The following is a description of a gene set: Human Gene Set: GOBP_SOFT_PALATE_DEVELOPMENT The biological process whose specific outcome is the progression of the soft palate from an initial condition to its mature state. This process begins with the formation of the structure and ends with the mature structure, whatever form that may be including its natural destruction. The soft palate is the posterior portion of the palate extending from the posterior edge of the hard palate. species: Homo sapiens, and this is the list of marker genes: TSHZ1, FOXE1, SOX11, COL11A2, TBX1